Given this list of marker genes Crhr1, Gabbr1, Vip, Crhr2, Ly6e (NCBI Gene Id 17069), Cartpt, Crh, Gck, Ptgs1, here is a description of the gene set: species: Mus musculus The regulated release of epinephrine by a cell. Epinephrine is a catecholamine hormone secreted by the adrenal medulla and a neurotransmitter, released by certain neurons and active in the central nervous system. Mouse Gene Set: GOBP_EPINEPHRINE_SECRETION